The following is a description of a gene set: Hydrolysis of a ubiquitin unit from a ubiquitinated protein linked via the Lys48 residue of ubiquitin. Human Gene Set: GOMF_K48_LINKED_DEUBIQUITINASE_ACTIVITY studied in species Homo sapiens, and this is the list of marker genes: USP8, MINDY2, USP7, USP26, MINDY1, DESI2, USP9X, OTUD5, MINDY4B, MINDY4, USP36, MINDY3, ATXN3, USP15, USP13, YOD1, CYLD (NCBI Gene Id 8010), OTUD7B, USP27X